Given this list of marker genes CACNA1D, TBX18, ANK2, GJC1, GJA5, CACNA1G, HCN4, HCN1, SCN5A, RYR2, SCN3B, HCN3, KCNA5, here is a description of the gene set: Human Gene Set: GOBP_SA_NODE_CELL_TO_ATRIAL_CARDIAC_MUSCLE_CELL_COMMUNICATION species: Homo sapiens The process that mediates interactions between an SA node cardiomyocyte and its surroundings that contributes to the process of the SA node cardiomyocyte communicating with an atrial cardiomyocyte in cardiac conduction. Encompasses interactions such as signaling or attachment between one cell and another cell, between a cell and an extracellular matrix, or between a cell and any other aspect of its environment.